Given this list of marker genes PLAAT4, RBFA, ENSG00000284948, CILP2 (NCBI Gene Id 148113), LRRK1, METTL5, BLOC1S1, RPL27A, CFAP61, SLC4A10 (solute carrier family 4 member 10), FRG1BP, CCDC91, PRTN3, PWP2, ARFIP1, FER1L4, TBC1D9, GDPD2, PKD1P1, OR4D9, DIO2, BTBD3, HEATR9, DUSP8, UBE3B, FRMD5, SERPINA3, PDE4DIP, RASGRP3, GPR21, VPS50, DGKE, KCNJ12, ZNF84, SCN9A, ZFP82, LRRC23, SPDYE7P, OR4C6, MYO9B, ATP5PO, ARHGEF11, FRG2, TCTN3, CRTC2, ZNF788P, FAM156A, DHX35, ABTB3, ADH6, RBM11, ACKR3, CHST6, FOXB1, NPAT, MRGPRG-AS1, PMCH, OR4N4, ATP2A2, MMD, SNRNP40, MEG3, H2BC18, PAK1, NDUFS3, NUP210, SLC8A3, PDGFRA, PPP2R2D, TSC22D1, MRPL52, SYCE1, SOX15, SNAPC1, DOCK7, SLC6A2, WNT9B, TNKS1BP1, PEMT, ZFP2, ZNF433, ANKRD9, ZNF641, VWA5A, SLC1A3, CEP76, DEFB129, DHODH, ANGPT1, CHTF8, ZNF561, DIXDC1, FBXO7, NKX2-1, NOXRED1, MSRA, H3-7, LIN7C, SPACA9, FADS1, CHD9, CYTH3, TUBGCP4, ARID3B, IL17D, ZNF785, E2F8, BPIFB1, DPP10, C20orf96, KRTAP5-9, IKBKG, PAWR, LCE3C, RIMBP2, FIGNL2, OR4N5, BCAS4, ALKBH1, SKAP1, NAALAD2, NCBP3, SPDYE8, CD2BP2, COL23A1, MKKS, IRAK4, ZNF534, ATP13A5, KBTBD4, CLCNKB, FLCN, FAM230I, MAPK8IP1, COCH, SRP14, SENP8, OR5AU1, HVCN1, SERPINC1, ACTR10, L1CAM, CCDC92, MPP1, RP9, KIF14, PLCB3, CLUHP3, IL24, OR8B4 (NCBI Gene Id 283162), THSD4, BDNF, SLC26A3, ARHGAP33, ZBTB7C, CHSY1, SNX14, UGT1A8, DPYSL3, AGPAT3, ZFP90, NPY4R, SMIM30, THBS4, PAK5, OR8K3, ROPN1, PLXNA4, COP1, TAAR8, TPTE2P6, ZNF239, OR13G1, NSA2, LYZL6, HSPB2, DDHD1, FAM72B, MINDY4, ZSCAN29, CHRNA2, FAM182A, DNMBP, FARSB, SYNE3, TNFAIP8, LINC00301, GAGE1, TOB1, ZNF182, SLC26A9, NOXO1, APPBP2, CAPN6, TSEN34, OR1A1, DNAH5, PAK2, ARIH1, STAMBPL1, ABCC13, JMJD6, NHSL2, LPAR2, KLRD1, ANO4, VCX, DAZ1, CYRIA, GOLGA6A, NFKB2, RHOF, COX7B, B3GALT2, PTPN20, BMP7, CSF2RB, MAMLD1, CABCOCO1, OTUD5, APOH, VCAM1, ZCCHC14, SEPTIN7, AMELY, SRGN, PLXDC1, SULT2B1, SLC39A1, EDN2, RBM12B, RARG, RFX7, SGPL1, ZNF576, RHOD (NCBI Gene Id 29984), SORBS2, MAP3K15, APBB1, CHMP1B, HORMAD2, FAM200C, CD69, SH3D19, IGFL4 (NCBI Gene Id 732176), CXCR5, LEMD1, HLA-DQA2, ABCA6, SIPA1L1, FBXL14, PHETA2, BTRC, AK8, WDHD1, STAG3L1, CEP83 (centrosomal protein 83), FAM72D, CLDN17, SPAG11B, RHOXF2, STC1, SPEF1, SGMS1, NPIPB3, F8A1, RNASE2, PMS2P13, STX1B, CST7, RAD51AP1, PTHLH, KRTAP15-1, ARHGAP19, DAZ4, EID1, PICK1, ZSCAN5A, KIF12, ZNF536, MC5R, ERRFI1, MTHFD2L, OR56A4 (NCBI Gene Id 79271), TRPC4 (transient receptor potential cation channel subfamily C member 4), SBNO2, ENSG00000204684, PMS2P5, CCDC42, TP53AIP1, PIGU, ORC6, ZNF664, CARD17P, MTF2, PKD1, ASAP1, CDH18, RHBDD1, PARD6B, CDH11, PCGF3, GTF2H3, SYTL5, ZFHX2, DBNL, TMEM132D, FRMPD2B, C19orf48P, KCTD10, KRT27, BMS1P21, PDS5B, FBN3, RBAK (NCBI Gene Id 57786), HOXC6, TLNRD1, KCNJ1, FRMPD2, SULF2 (sulfatase 2), YAF2, DAZ3, PTAFR, ALDH18A1 (aldehyde dehydrogenase 18 family member A1), AP1M2, FGFR2, GADD45G, ISCU, ARMH4, DCN, PSMG2, AKAP10, SLC36A1, RPS10P7, ALDH3A2, SMDT1, CREB3L4, CEP295, GAS2L3, FAM47C, MAGEA10, CBFA2T2, GAS2, SART3, C15orf48, GUSBP1, MCRIP1, KCNMA1, TLE5, DDX39A, KRTAP11-1, ASXL3, SHCBP1, ERCC4, AGBL3, GLRA3, TCEAL4 (NCBI Gene Id 79921), CNTN1, POM121, UBL7, VN1R4, RRP7A, SQLE, LMO3, PTGDR2, RFLNA, AMBRA1, PCP4, ATP13A4, HOXC5, TTLL6, PIEZO1, OR52I1 (NCBI Gene Id 81260), AVP, KLF8, SOCS4 (NCBI Gene Id 122809), CBX5, PAMR1, IGLL1, VPS35, ZNF541, CRTAC1, GMCL2, TBXA2R, RAB40AL, UPB1, OGFOD1, TPT1 (tumor protein, translationally-controlled 1), WDR6, FGFR1OP2, NDUFAB1, TAS2R46, CRYBB3, PLAC9, GLB1L3, PPIP5K1, GAGE12F, GFER, PSEN1, BCO2, ZCCHC17, DDX12B, PDE6H, MAP1LC3C, OSBP, TRIM39, TIGD4, PGAP6, RNASE3, SPTLC2, WDR86, SMG1, NPIPB1P, OR5L1, BPESC1, SLC38A10, GLG1, DIPK1A, FERMT2, VPS11, OR1A2, PEX3, ZNFX1, CLPTM1L, VPS4B, ODAD3, RUNX1, SGSM1, CRISP2, AVPI1, LIG3, PGM2L1, KLF5, CGB7, FGL1, LIN54, FCHSD2, PRR4, ATM, MEGF10, GPR65, CASP1, CARD8, CD6, SPX, CRNKL1, NOLC1, IGLV4-3, C10orf120, CHCHD5, USP32P2, TMEM30B, SUSD4, RPS11, SLC44A1, ZFYVE27, DAZ2, OR1S1, RAB9A, STON2, ARMH3, here is a description of the gene set: Human Gene Set: MCCABE_BOUND_BY_HOXC6 Homeobox transcription factors are developmentally regulated genes that play crucial roles in tissue patterning. Homeobox C6 (HOXC6) is overexpressed in prostate cancers and correlated with cancer progression, but the downstream targets of HOXC6 are largely unknown. We have performed genome-wide localization analysis to identify promoters bound by HOXC6 in prostate cancer cells. This analysis identified 468 reproducibly bound promoters whose associated genes are involved in functions such as cell proliferation and apoptosis. We have complemented these data with expression profiling of prostates from mice with homozygous disruption of the Hoxc6 gene to identify 31 direct regulatory target genes of HOXC6. We show that HOXC6 directly regulates expression of bone morphogenic protein 7, fibroblast growth factor receptor 2, insulin-like growth factor binding protein 3, and platelet-derived growth factor receptor alpha (PDGFRA) in prostate cells and indirectly influences the Notch and Wnt signaling pathways in vivo. We further show that inhibition of PDGFRA reduces proliferation of prostate cancer cells, and that overexpression of HOXC6 can overcome the effects of PDGFRA inhibition. HOXC6 regulates genes with both oncogenic and tumor suppressor activities as well as several genes such as CD44 that are important for prostate branching morphogenesis and metastasis to the bone microenvironment. from publication McCabe CD, Spyropoulos DD, Martin D, Moreno CS (PMID 18339881) studied in species Homo sapiens Genes whose promoters where bound by HOXC6 in LNCaP cells (prostate cancer), according to a ChIP-chip analysis.